Given this list of marker genes SHOC2, EPO, NGF, RASGRF1, CSF1, IGF1 (NCBI Gene Id 3479), NOTCH2 (NCBI Gene Id 55574), KITLG, RASGEF1A, NOTCH1, ITPKB, MAP2K1, MMD2 (monocyte to macrophage differentiation associated 2), PICALM, NTRK1, STK19, FGF10, RASGRP1, here is a description of the gene set: studied in species Homo sapiens Any process that activates or increases the frequency, rate or extent of Ras protein signal transduction. Human Gene Set: GOBP_POSITIVE_REGULATION_OF_RAS_PROTEIN_SIGNAL_TRANSDUCTION